The following is a description of a gene set: species: Mus musculus Any process that activates or increases the frequency, rate or extent of the chemical reactions and pathways involving sulfur or compounds containing sulfur. Mouse Gene Set: GOBP_POSITIVE_REGULATION_OF_SULFUR_METABOLIC_PROCESS, and this is the list of marker genes: Ctnnb1, Sp1, Comt, Pxylp1, Tcf7l2, Eif2ak3, Nfe2l2